Given this list of marker genes RORA, PPARA, RORC, NCOA6, TGS1, HDAC3, MED1, TBL1XR1, EP300, CARM1, TBL1X, RXRA, NRIP1, USP46, SREBF1, PPARGC1A, SMARCD3, NCOR1, NCOA2, NR1D1, CPT1A, NCOA1, CREBBP, HELZ2, CHD9, ELOVL3, here is a description of the gene set: Human Gene Set: REACTOME_RORA_B_C_AND_NR1D1_REV_ERBA_REGULATE_GENE_EXPRESSION RORA,B,C and NR1D1 (REV-ERBA) regulate gene expression studied in species Homo sapiens